The following is a description of a gene set: species: Mus musculus Mouse Gene Set: GOBP_ADIPOSE_TISSUE_DEVELOPMENT The process whose specific outcome is the progression of adipose tissue over time, from its formation to the mature structure. Adipose tissue is specialized tissue that is used to store fat., and this is the list of marker genes: Ap1s2, Csf1, Hras, Id2, Lrp5, Paxip1, Ifrd1, Dhrs7b, Errfi1, Adrm1, Amer1, Hsd17b1, Tbl1xr1, Acat1, Ncoa1, Enpp1, Umodl1, Asnsd1, Pparg, Lep, Sh3pxd2b, Mir103-2, Sox8, Ncoa2 (NCBI Gene Id 52119), Sirt1, Rorc, Casr, Pou4f2, Trpm4, Chaserr, Xbp1, Ppard, Zfp516, Mir143, Bscl2, Gpr82, Lncpint, Hmga2, Rasal2, Lipa, Slc25a25, Pum2, Bbs4, Lmna, Ghrl, Arid5b, Selenom, Ebf2, Sptlc2, Bltp1, Cd2ap, Lpl, Vps13b, Pik3ca, Nmnat1, Arrdc3, Spi1, Norad, Fgl1, Klf7, Fosl2, Parp1, Hmgcs2, Dyrk1b, Creb5, Ifrd2, Mir103-1 (NCBI Gene Id 723824), Fto, Ubb, Ppargc1a, Dgat2, Atf2, Sorl1, Prkaa1, Pgrmc2, Plaat3, Guca2b, Nr1h4, Abhd15, Gm15290, Spart, Col6a1